The following is a description of a gene set: An abnormal morphology of the olfactory bulb (bulbus olfactorius), which is involved in olfaction, i.e. the sense of smell. Human Gene Set: HP_ABNORMAL_MORPHOLOGY_OF_THE_OLFACTORY_BULB Abnormal morphology of the olfactory bulb species: Homo sapiens, and this is the list of marker genes: SIX3, TUBB2B, SMCHD1, PROKR2, TGIF1, FOXH1, PTCH1, KIF21A, ERBB3, GSX2, GAS1, KIAA0586, CILK1, PHOX2A, STAG2, GLI2, FOXP2, PROK2, POU3F3, SMC1A, DLL1, CRIPTO, NODAL, PLCH1, ZSWIM6, TUBB3, SHH, CDON, COL25A1, DISP1, FGF8, SEMA3A (semaphorin 3A), TUBA1A, FGFR1, ZIC2, STIL